Given this list of marker genes Stx1b (syntaxin 1B), Snap23, Vamp3, Stx12, Stx8, Use1, Stx7, Stx2, Snap47, Vti1a, Vamp2, Bet1, Gosr2, Ykt6, Sec22b, Stx4a, Vamp9, Stx6, Snap25, Stx3, Stx19, Stx17, Pick1, Vti1b, Stx16, Vamp1, Stx1a, Stx5a, Stx11, Stx18, Gosr1, Vamp8, Bet1l, Snap29, Bnip1, here is a description of the gene set: Acting as a marker to identify a membrane and interacting selectively with one or more SNAREs on another membrane to mediate membrane fusion. Mouse Gene Set: GOMF_SNAP_RECEPTOR_ACTIVITY species: Mus musculus